The following is a description of a gene set: studied in species Mus musculus Any process that modulates the frequency, rate or extent of skeletal muscle cell proliferation. Mouse Gene Set: GOBP_REGULATION_OF_SKELETAL_MUSCLE_CELL_PROLIFERATION, and this is the list of marker genes: Paxbp1, Shh, Mstn, Ephb1, Fgf2, Six1, Six5, Ppard, Selenon, Jak2, Akirin1, Sirt1, Stat3, Cav2, Myog, Angpt1, Cflar